The following is a description of a gene set: Human Gene Set: HP_MANDIBULAR_APLASIA Absence of the mandible. Mandibular aplasia studied in species Homo sapiens, and this is the list of marker genes: FAM20C, CDT1 (NCBI Gene Id 81620), ORC6, ORC4, HCCS, PRRX1, CDC45, OTX2, CDC6, ORC1 (NCBI Gene Id 4998), NDUFB11, COX7B, GMNN